Given this list of marker genes IRF7, HCFC1, LIG4, JUN, CREB3, here is a description of the gene set: The process by which, after initial infection, a virus lies dormant within a cell and viral production ceases. The process ends when the virus switches from latency and starts to replicate. Human Gene Set: GOBP_VIRAL_LATENCY studied in species Homo sapiens